Given this list of marker genes Ctc1, Pola2, Acd, Pot1a, Rpa3, Pold2, Chtf18, Prim2, Pold3, Terf1, Prim1, Dna2, Wrn, Terf2ip, Dscc1, Stn1, Pold1, Ten1, Lig1, Rfc1, Rpa2, Pcna, Rfc4, Pold4, Blm, Terf2, Chtf8, Rfc2, Fen1, Rpa1, Rfc3, Rfc5 (replication factor C (activator 1) 5), Pola1, here is a description of the gene set: Mouse Gene Set: REACTOME_TELOMERE_C_STRAND_LAGGING_STRAND_SYNTHESIS studied in species Mus musculus Telomere C-strand (Lagging Strand) Synthesis